Given this list of marker genes OR13H1, STK24P1 (serine/threonine kinase 24 pseudogene 1), INTS6L, MAGEA13P, CT45A5, INTS6L-AS1, SRRM1P3, HPRT1, APLN, MIR450B, LARP1BP3, ETDB, RAP2C-AS1, BCORL1, GPR119, ETDC, CCDC160, SMIM10L2B, CROCCP1, PNKDP1, ENSG00000287024, RNA5SP515, CT45A1 (NCBI Gene Id 541466), KRT8P6, SAGE2P, FHL1, RTL8C, TM9SF5P, ENSG00000297976, RNU1-115P, RN7SL191P, MIR106A, SPRING1P2, GPC4, RNU6-320P, IGSF1, NAA20P1, MIR503HG, E2F6P4, OR11N1P, SMARCA1, NT5DC1P2 (NT5DC1 pseudogene 2), ENSG00000252170, CT45A11P (cancer/testis antigen family 45 member A11, pseudogene), OR5BH1P, FGF13-AS1, AGKP2, HTATSF1, HS6ST2, FIRRE, OR5AW1P, RAB33A, MIR542, TFDP3, ZFYVE9P1, PLAC1, CT45A7, RAC1P4, MOSPD1, SMIM10L2A, LINC00892, RAB28P5, SMIM10L2B-AS1, FRMD7, CD40LG, OCRL, MGAT2P2, SLC25A14, ENSG00000207100, RBMX2, CT45A2, ENSG00000286060 (NCBI Gene Id 124905218), RPS24P19, STK26, RNU6-203P, MCRIP2P1, LINC02931, RN7SL325P, RPL22P23, RTL8B (retrotransposon Gag like 8B), SAGE4P, GAPDHP67, RPL7P56, RNA5SP514, LINC02243, ENOX2, CT45A8, RNU6-98P, SASH3, RNU6-985P, RPL21P133, USP26, SLC9A6, SAGE3P, OR2AF1P, RN7SKP31, RPSAP63, MIR363, SALL4P2, H2AQ1P, CT45A9, MIR92A2, OR13K1P, TIMM8BP2, MIR18B, MIR424, HMGB3P31, CT55, MIR106AHG, UTP14A, RPS7P12, BRS3, RBMX, GPC3-AS1, VGLL1, SNORD61, ETDA, ZNF75D, SAGE1, ZIC3, HS6ST2-AS1, RPL36AP54, CT45A10, ZNF449, CT45A3, MIR934, NCLP2, HDGFP1, RAP2C, RNU6-1130P, GPC3, RANP4, MIR450A1, RNU4-44P, OR11Q1P, XPNPEP2, ADGRG4, AIFM1, ARHGEF6, MIR450A2, TPM2P1, ELF4, MIR19B2, GPR101, PABIR3, ENSG00000239080, ZNF280C, MAP7D3, PABIR2, RTL8A (NCBI Gene Id 84714), WDR4P1, RNU6-972P, NLRP7P1, DENND10P1, MGAT2P1, ETS2P1, LINC00629, MMGT1, LINC01201, RNU6-616P, MIR20B, PHF6, MIR503, OR1AA1P, ARHGAP36, MIR504, MBNL3, ZDHHC9, CT45A6, SMIM10, OR7L1P, FSIP2LP, here is a description of the gene set: Human Gene Set: chrXq26 species: Homo sapiens